Given this list of marker genes Nalcn, Tacr2, Tacr1, Tac1, Adora2a, Uts2, Htr2c (5-hydroxytryptamine (serotonin) receptor 2C), Lama2, Slc18a3, Ifng, Musk, Ngfr, here is a description of the gene set: Mouse Gene Set: GOBP_POSITIVE_REGULATION_OF_SYNAPTIC_TRANSMISSION_CHOLINERGIC studied in species Mus musculus Any process that activates, maintains or increases the frequency, rate or extent of cholinergic synaptic transmission, the process of communication from a neuron to another neuron across a synapse using the neurotransmitter acetylcholine.